The following is a description of a gene set: species: Homo sapiens Human Gene Set: MIR30A_3P from publication Chen Y, Wang X (PMID 31504780) Genes predicted to be targets of miRBase v22 microRNA hsa-miR-30a-3p in miRDB v6.0 with MirTarget v4 prediction scores > 80 (high confidence targets)., and this is the list of marker genes: UBR5, KLHL5, HMGA2, SNRK, LSS, RYR3, SESTD1, ZBTB41, FAM98A, CCDC184, COLEC12, PDK4, CDC73, DEUP1, MYO5C, SLITRK3, AKAP5, ERAP1, DBT, ZNF35, MEI4, INTS8, GATC, GM2A, FBXO22, GPR180, CHCHD4, ECM2, TULP4, CNPY2, TOMM20, RUNX1T1, FXR1, TPK1, PRLR, NAA25, NR3C1, TUSC3, ARID4A, SPIRE2, RGS7BP, TNFSF13B, TCEAL6, ARMC1, PIH1D2, ZNRF3, USP1, CSNK1E, CEP19, CDKN1B (NCBI Gene Id 1027), UBXN2B, PIAS1, ZNHIT6, TPR, HMGN4, CALCA, MAP1B, GPR137C, VANGL1 (NCBI Gene Id 81839), NOD1, PALS2, RELT, DAZ2, PTEN, ETNK1, VCPIP1, MNT, NPY2R, DHFR, BRD8, ATRN, CANX, SH3GL3, TOB1, ABHD5, BCCIP, KMT5B, SGMS2, GUCY1A2, B9D1, ASXL3, IARS2, TRIM72, AP4E1, KMT2A, BRWD1, POU2F1, ITGA1, CCDC112, ZC3H14, EMC4, LRRTM2, EIF2AK1, CAST, RFK, TRIM33, FAM171B, ZNF704, ADA, TUBGCP5, YWHAE (tyrosine 3-monooxygenase/tryptophan 5-monooxygenase activation protein epsilon), MAGT1, TWNK, USP38, ZNF426, CCN3, SLC5A3, ZFHX3, PMEL, XPNPEP3, HYCC1, VGLL3, POU4F1, FAR1, MED12L, PHACTR2, PANK3, PIK3AP1, RGS7, CENPL, CEP350, SP3 (Sp3 transcription factor), RNF216, PAG1, CLDN14, MCCC2, PCDH17, RTP4, SLC27A6, APC, SS18, PYROXD1, FANCD2, SLC35F3, STAU1, PIAS2, SYT4, IPCEF1, HOOK1, CDC40, SNAP91, HSPA5, TMPRSS11D, DLST, ZNF430, ANTXR2, YARS2, TMEM47, GTPBP4, MAP3K4, EPGN, NEMP1, CHMP1B, DOCK1, CACNB4, WDR44, SCAF4 (SR-related CTD associated factor 4), FBXL20, PTPN21, ACTR2, PRKAA2, CMKLR2, PCSK5, PPM1B, CCKBR, FGF7, GALNT7, STK38L, RUNX2, AR, GFPT1, DNAI4, SESN3, APOBEC3A, SUV39H2, RNF6, ARF6, PRDM11, ZDHHC21, GGH, RAB3IP, SYNJ2, SAMTOR, COL12A1, SLITRK6, SEMA3C, DTNA, GABRG2, RALA, CCDC6, SH3GLB1, KANSL1L, ELAPOR2, PDE12, RBM7, DOP1B, LCORL, DNAJB9, NCOA7, METTL4, CCDC80, CAPRIN1, SEC62, ZNF566, INO80C, SLC12A6, SMG1, DNAJB14, MSR1, PLEKHH1, SOCS6, CALHM5, ROBO1, KRBA2, IL1B, SH3D19, GPRASP2, PTPN3, C8orf44, NR2C2, SH2D3A, LRP8, LACTB, RIF1, BTNL9, COCH, CAV1, VCF1, OPRK1, MYSM1, ATP9B, RBM45, PSMD10, MAP3K2, ELOC, EOGT, THOC2 (THO complex subunit 2), SYNRG, PRPH2, MRPL30, NKRF, ZNF107, NPAT, ROR1 (receptor tyrosine kinase like orphan receptor 1), YTHDF3, YPEL5, STIM2, SMAD2, ZNF827, UBE2J1, NSL1, SUB1, P2RY1, FCHO2, GOSR1, PCLO, GPR158, SSR1, KRT6C, RUNX1, TSHR, CDKL2, CWF19L2, CSNK1G3, NAA16, EXTL2, PAIP2, PSD3, HIRA, NPHP3, PSIP1, DIP2B, CHURC1, HS3ST1, PDXDC1, LRCH1, OTUD6B, CEP152, KCTD16, PHF24, CREBBP, NHS, SERTAD2, SLC12A1 (NCBI Gene Id 6557), DNAJB4, TENM1, ZNF138, ELK3, LPGAT1, RNF141, NUFIP2, AAK1, TSPAN13, UBE2G1, EPS8, TCP11L1, SEMA3E, NEGR1, KLHL11, TEAD1, MYO5A, NTRK3, OSBPL11, SEMA6D, MTHFD2, CACYBP, SCAF11, ROCK2, SOS2, FAM20B, TTPAL, ATP11C, AKT3, ZNF280B, MEOX2, SASS6 (SAS-6 centriolar assembly protein), SYT14, CCDC186, SLC10A7, NAPG, SBNO1, UFSP2, TXLNB, SLC25A33, RB1, MARS2, COL4A4, DACH1, RAB8B, RALGPS2, NBEAL1, PIGBOS1, GALNT1, SOD2, ZCCHC14, TLK2, HS3ST5, CREB1, ACBD3, CEP44, RANBP3L, GNA12, TBC1D23, PDK1 (NCBI Gene Id 5163), ARHGAP28, MRTFB, HOXB7, ZCCHC10, POGLUT3, EPAS1, GBP1 (guanylate binding protein 1), EGR1, ARL11, PRDM10, MFAP4, NOX3, C5orf24, ZBTB18, GPR176, MINDY2, MTDH, TRMT10B, HDX, CDKL5, SLC36A4, SLC39A10, PHLDA1, OSBPL1A, SGCZ, UBL3, RCN2, EP300, KRT10-AS1, TPTEP2-CSNK1E, TNRC6B, SCAI, PPP1R3A, FAM114A2, ZEB2, SLC6A3, NODAL (NCBI Gene Id 8114), NABP1, IGF1, SNX18, RNF217 (ring finger protein 217), SELENOT, ADAMTS5, SRSF4